Given this list of marker genes NFKB1, IKBKG, RELA, IKBKB, CHUK, NFKBIA, here is a description of the gene set: studied in species Homo sapiens Human Gene Set: KEGG_MEDICUS_PATHOGEN_KSHV_VFLIP_TO_NFKB_SIGNALING_PATHWAY Pathway Definition from KEGG: vFLIP -> IKK -> NFKBIA -> NFKB KSHV vFLIP to NFKB signaling pathway. Pathway ID: N00171. Pathway type: Pathogen. Pathway class: nt06516 TNF signaling.